The following is a description of a gene set: from publication Baek D, Villén J, Shin C, Camargo FD, Gygi SP, Bartel DP (PMID 18668037) This array analysis is to study the regulation of target messages’ expression in murine neutrophils versus miR-223 null neutrophils. Genes up-regulated in neutrophils: MIR223 knockout versus wildtype. Human Gene Set: GSE12001_MIR223_KO_VS_WT_NEUTROPHIL_UP studied in species Homo sapiens, and this is the list of marker genes: SUCLG2, RBM25, BOLA1, MCRIP2, RNF114, CMTR2 (cap methyltransferase 2), SLC37A1, TFDP1, NR4A2, CDK4, NONO, COX10 (NCBI Gene Id 1352), ADAP1, PTP4A1, FKBP4, CASP4, TCF4, PABIR1, RRAS2, SLC25A19, SGF29, TDP1, TUFT1, RPL34, HNRNPLL, MRPS17, IL2RB, PRKRIP1, PRMT6, RRN3 (RRN3 homolog, RNA polymerase I transcription factor), PCBP3, BMS1, SYTL1, HOOK1, XBP1, PRPF38A, PECR, DEPDC1B, ALCAM, AATF, AIMP1, PDK3, GLRX (NCBI Gene Id 90885), ACSL4, SLC25A25, SLC25A22, MAPK11, GTF2H4, TLE1, DLGAP5, VPS37C (NCBI Gene Id 55048), ABCE1, CREB1, DHPS, ISG20, CMPK2, DNAJC3, SVIL, AHCY, CERS2, RFNG, SLC25A51, SHCBP1, SRC, MIR17HG, VPS33B, ID1, MRPL30, FHL2, GUK1, PA2G4, PARL, PGS1, TRAP1, TYROBP, NUP54, CAP2, ANKRD49, SKIC3, POMGNT1, CNN3, GMDS, MINDY3, EIF5, PDCD10, ATPSCKMT, ANP32E, MRPL28, CFDP1, RAB5C, DIPK1B (NCBI Gene Id 138311), TYW1, DDX41, PMP2, MRPL37 (NCBI Gene Id 51253), RBM15, PIK3AP1, MED18, ATG16L1, GZMK, RHBDF2, CCNO, FRMD4B, MRPL51, PTBP1, NKRF, INSM1, NUP43, APOH, GTF3C4, SEMA4B, CCT2, GRPEL1, HERC5, TNIP3, UQCRQ, DNAJC21, SGO1, MPHOSPH6, ERI1 (NCBI Gene Id 90459), GEMIN4, ST14, DOCK4, PRRG4, CTNNBL1, SCO1, NFIL3, ZZZ3, HSF1, PRPS1, KANK3, PTAR1, SHQ1, POLR1F, SMN1, UTP3, THUMPD1, H2AC8, LMNB1, SLC25A26, ZCCHC10, AFG2B, PHF6 (PHD finger protein 6), CLPP, ZDHHC13, STAT3, TAF11, QDPR, UNK, RPS25, AHCYL1, BBS12, HEATR1, DNAJA2, DKKL1, PRELID3B, EEFSEC, PRMT3 (NCBI Gene Id 10196, protein arginine methyltransferase 3), TNFRSF25, GRK5, CTLA4, DCPS, MRPS18A, HAUS2, TLR7, NEMP1, CLTC, CRYBG1, STAP1, PPP1CC, CXCL2, UTP25, XRCC2, DBNL, PPP1R7